Given this list of marker genes S100a6, Phgdh, Pde3b, Rrbp1, Gpt2, Ube2d-ps, Wars1, Mettl2, Nr1i3, Ugdh, Ppp1r15a, Mthfd2, Man2c1os, Psph, Slc4a10, Nfatc1, Tfap2a, Cth (NCBI Gene Id 99582), Spp1, Rapgef6, here is a description of the gene set: Mouse Gene Set: TERAMOTO_OPN_TARGETS_CLUSTER_7 Cluster 7: genes down-regulated early (within 24 h) after knockdown of OPN by RNAi in the NIH3T3 cells (fibroblasts) transformed by activated HRAS. species: Mus musculus Activated forms of Ras family members are prevalent in many cancers where Ras mutants transduce signals essential for transformation, angiogenesis, invasion and metastasis. As a cancer progression model, we used NIH3T3 cells to explore the mechanism of Ras-induced tumorigenesis. Ras family mutants H-RasV12 and Rit79L strongly induced foci formation, while Rho family mutants RhoA-QL, Rac1-QL and Cdc42-QL were less effective. A comparison of downstream transcriptional targets of Ras and Rho family members using a 26 383 element cDNA microarray revealed that the osteopontin (OPN) gene exhibited the best correlation between magnitude of gene expression change and level of foci formation (r=0.96, P<0.001). In association with H-RasV12- and Rit79L-mediated transformation, foci secreted OPN protein and upregulated the OPN receptor CD44, suggesting the novel initiation of an aberrant OPN-CD44-Rac autocrine pathway. In support of this were the following observations. First, RGD-deficient OPN protein-binding activity was present in H-RasV12-transformed cells but not in control cells, and binding activity was inhibited by the CD44 blocking antibody. Second, foci formation, cell invasion and Rac activity were induced by H-RasV12 and inhibited by the CD44 blocking antibody. Third, foci formation by H-RasV12 was substantially reduced by a short interfering RNA (siRNA) specifically targeting OPN expression for knockdown. Fourth, H-RasV12-mediated transformation was not blocked by the GRGDS peptide, suggesting that OPN effects were not mediated by the integrins. Lastly, OPN knockdown affected the downstream expression of 160 '2nd tier' genes, and at least a subset of these genes appears to be involved in transformation. Indeed, four genes were selected for knockdown, each resulting in a disruption of foci formation and/or invasion. These results underscore the role of aberrant autocrine signaling and transcriptional networking during tumorigenesis. from publication Teramoto H, Castellone MD, Malek RL, Letwin N, Frank B, Gutkind JS, Lee NH (PMID 15516973)